The following is a description of a gene set: from publication Chen Y, Wang X (PMID 31504780) species: Homo sapiens Genes predicted to be targets of miRBase v22 microRNA hsa-miR-425-5p in miRDB v6.0 with MirTarget v4 prediction scores > 80 (high confidence targets). Human Gene Set: MIR425_5P, and this is the list of marker genes: TDRD5, CFL2, MARK1, SMG1, TRMT13, SENP6, SHISA7, BCAS2, CAB39, DNAJC27, CYYR1, DYNC2H1, ANKRD1, NUFIP2, ZNF124, TMEM116, DEK, TMEM135, MBD1, SPTLC3, USP54, PDCD10, FAM13B, KCNT2, GPATCH2L (NCBI Gene Id 82392), GINS1, FOXJ3, VRK2, PPP2R2A, KLHL13, CENPT, PTPRN2, RNF217, RAB3C, EDIL3, DICER1, EPPK1, SAMD4A, SCAMP1, GPRASP3, TMEM263, IL11, PPP4R3A, ATP5MC3, CDC14A, RIT1 (NCBI Gene Id 6016), ARMC8, CDC5L, VIT, SLC6A1, SIDT2, MAP3K5, ZMAT3, ZFP82, SMAD5, SYNCRIP, ELOVL5, AP3M1, CYBB, FASTKD3, BEX4, SMCHD1, BCOR, WAPL, SH3RF1, PRDM8, CADM4, RGS13, BRD10, FAM204A, PUS7L, CD36, MAP2K6 (mitogen-activated protein kinase kinase 6), KCNK9, VPS26B (VPS26 retromer complex component B), AJAP1, CBX6, NRAS, DIP2C, HGF, GABRA1, ZBTB21, MPZL1, ADCY1, EOGT, MINDY2, FBXO45, GPC6